Given this list of marker genes CENPH, PLD4, CD2, MPEG1, CTNNA1, SPI1, CD74 (NCBI Gene Id 972), CDC25C, S100A6, TMEM176B (transmembrane protein 176B), LPCAT3, TRIP13, MYO1G, DTL, CPD, USP10, KLF17, NUF2, ANLN, WDFY4, NCAPD2, HYCC1 (NCBI Gene Id 84668), CTSH, HAT1, MYC, KIF11, ANXA4, XBP1, INCENP, SDC4 (syndecan 4), AHCYL2, LYN, KIF4A, SRSF2, GTSE1, BANK1, LY96, DDOST, CFAP144P1, ENTPD1, SYPL1, TNFRSF4, TRAF7, KIF20B, TPX2, CCR6, ECM1, TNIP3, MED7, LIG1, PLIN2, IFI30, MCRS1, CAPG, SERPINA9, PIK3C2B, HSP90AB1, CD24, CENPI, GSTT2, B4GALT5, PRC1, DET1, SNRPD1, TEX15, MKI67, H4C8, CD79B, SLC37A2, ECT2, CLSPN, TGM2, CD38, MS4A1, BLK, PIM1, CRYL1, CASP8, NAPSA, EGR2, MYO1C, EVI5, CR2, CSTB, NUP205, PPARG, CD79A, MYO1E, FCRLA, NIBAN1, BID (BH3 interacting domain death agonist), NKG7, RALGPS2, EIF4B, CDCA2, CKS1B, PLK2, IRF4, ITPR1, GRN, CANX, KIF15, FCMR, DNAJB13, CCNA2, SLC43A3, LY6D, SEMA7A, CYFIP1, TNFRSF13C, SCD, ODC1, ETFB, CD83, KIF23, CCNF, IGF2BP3, SHCBP1, CD19, ADAM9, CYBB (NCBI Gene Id 1536), KMO, NUDT22, CD22, CFP, ASF1B, STIL, LY86, KNTC1 (NCBI Gene Id 9735), COBLL1, UBE2L3, TCF19, CISH, SLC43A1, BUB1B, HMMR, CXXC5, NFKBIZ (NCBI Gene Id 64332), DGAT1, SPIB, HDAC1, HMGN3, ERGIC3, POLE2, GZMB, PPP2R3A, MIS18BP1, E2F8, CARS1, POLR1H, MEF2C, EHD4, CENPE, RASGRP3, SLC27A2, FCRL1, BLNK, MVP, TXNDC5, PROS1, TK1, CCR4, IMPA2, EEA1, CTSZ, TCF4, TNFRSF18, KNL1, LAT2, VAV2, CKAP2L, TNFRSF9, here is a description of the gene set: Human Gene Set: GSE32901_NAIVE_VS_TH17_NEG_CD4_TCELL_UP In this study, we examined differential gene expression in naïve human CD4+ T cells, as well as in effector Th1, Th17-negative and Th17-enriched CD4- T cell subsets. We observed a marked enrichment for increased gene expression in effector CD4+ T cells compared to naive CD4+ among immune-mediated disease oci genes. Within effector T cells, expression of disease-associated genes was increased in Th17-enriched compared to Th17-negative cells. We used microarray to examine the gene expresssion profile and level of human naïve, Th1 and effector T cell subsets. species: Homo sapiens Genes up-regulated in CD4 T cells: naïve versus Th17 negative. from publication Zhang W, Ferguson J, Ng SM, Hui K, Goh G, Lin A, Esplugues E, Flavell RA, Abraham C, Zhao H, Cho JH (PMID 22715389)